The following is a description of a gene set: species: Homo sapiens An abnormality of the dermatoglyphs, i.e., an abnormality of the patterns of ridges of the skin of palm of hand. Abnormal palmar dermatoglyphics Human Gene Set: HP_ABNORMAL_PALMAR_DERMATOGLYPHICS, and this is the list of marker genes: CILK1, PEX26, RPL10, ALDH6A1, SMC3, TRIM8, DPAGT1, AIP, MTX2, H3-3A, SPRTN, TOE1, BRF1, MCTP2, NAA20, PDHA1, POLRMT, BMP4, SMPD4, H4C9, IFT57, SETBP1, RTL1, CCNQ, PEX14, GLE1, PPP3CA (protein phosphatase 3 catalytic subunit alpha), FOXP1 (NCBI Gene Id 87246), MEGF8, PEPD, NSDHL, KAT6B, ZMYM2, BICD2, CKAP2L, BHLHA9, APC, DDX11, RIPK4, TNNT3, ITCH, GJA5, GPR101, ASXL3, NEXMIF, KRAS, PPP2CA, RPS23, CSGALNACT1, TSEN34, PKDCC, DSE, NUP188, SPECC1L, ARID1B, NUP88, DHX30, VPS51, FIG4 (NCBI Gene Id 9896), THOC2, ZFX, VPS33A, FLNA, TRIM37, NAA10, PEX6, MUSK, DOCK6, TNNI2, BRD4, TSEN15, DOK7, EXTL3, TGDS, ANKRD11, TMEM147, FILIP1 (NCBI Gene Id 27145), JARID2, PEX11B, NGLY1, IFT43, PUF60, AFF3, PEX3, TBX5, PORCN, TAF4, SMARCA2, TBL1XR1, PLOD3, COX14, ZNF462, KATNB1, RAB11B, ASXL1, ATP6V0A2 (NCBI Gene Id 7854), MAP2K2, PEX16, CHST14, DLK1 (NCBI Gene Id 8788), CDK10, PEX5, SMARCAD1, GDF5, RNU4-2, MEF2C, GLYCTK, SET, EHMT1, PEX12, DPH2, PEX19, DPH1, TPM2, GRIN1, CHD7, CDC42BPB, SPRED2, PEX1, TBX4, DPYD, PRR12, FGF9, ATP6V1A, SLC39A13, TRPS1, VPS13B, MAP1B, B3GLCT, SMC5, ESCO2, DIS3L2, EP300, CDK19, LTBP4, LTBP1, SMOC1 (NCBI Gene Id 64093), AHDC1 (NCBI Gene Id 27245), HCCS, PACS1, FBXO11 (NCBI Gene Id 80204), B4GALT7, ADAMTSL1, CLCN7, STAG1, TCF12, XYLT1, TAF6, EZH2, MAGEL2, NBAS, CTCF, PTPRF, KDM4B, BMPR1B, POLR1A, OTUD5 (NCBI Gene Id 55593), SLC25A12, U2AF2, CTBP1 (NCBI Gene Id 1487), PEX13, DEPDC5, KCNN3, FGFR3, RAPSN, UFC1, PIEZO2, PEX10, MTOR, TYMS, FBXO28, MAP2K1, KDM6A, CEP55, SMC1A, UBE3B, HNRNPK, KMT2D, TRIO, FGD1, CREBBP, MYH3, SPTBN1, AUTS2, FGFR2, PLAA, PIGS, RPS6KA3, SMAD2, TCF4, TWIST1, SEPSECS, KCNK9, GNB2, KCNH1, ASXL2, MED12, RERE, RIN2, PGM2L1, HDAC8, EXT1, VAC14, NOG, CD96, RNU4ATAC, LMX1B, TELO2, ATP6V1B2, ATR, BRAF, COG1, TFAP2A, NSD2, PNPLA6 (patatin like phospholipase domain containing 6), CEP57, YY1, WDR37, NECTIN1, NXN, UBR7, LIFR, TASP1, SMS, SLC25A24, CPLX1, ARL3, MTFMT, ROR2, RBM10, NUP107, TSEN54, KIF21A, CCBE1, MYOD1, TUBA1A, NALCN, DLX4, MAP3K7, CHST3, GJA8, ZNF292, TBCK, RAD21, SHOC2, CSNK2A1, IFT122, G6PC3, HRAS (NCBI Gene Id 338029), SLC18A3, STXBP1, NIPBL, EBF3, HDAC4, WAC, MSL3, PIGA, IGF1, LETM1, BCOR, NDUFB11, PEX2, LONP1, UBR1, MEG3, TSEN2, COX7B, PPP2R3C, FGFRL1, ADNP, MED25 (NCBI Gene Id 81857)